The following is a description of a gene set: The developmental growth in which the ureteric bud grows along its axis beginning with the growth of the primary ureteric bud and ending when the branches of the bud have elongated. Human Gene Set: GOBP_URETERIC_BUD_ELONGATION species: Homo sapiens, and this is the list of marker genes: HNF1B, KIF26B, LZTS2, SIX1, FGF1 (NCBI Gene Id 29961), SIX4, SALL1